Given this list of marker genes DHX9 (NCBI Gene Id 3450), UBA52, RIPK3, DDX41, NFKB1, ZBP1, XRCC6, CTNNB1, CGAS, XRCC5, POLR2E, STAT6, RELA, NFKBIA, RIPK1, POLR3K, POLR1C, RPS27A, NFKB2, POLR2H (NCBI Gene Id 5437), TRIM21, IKBKG, NLRC3, NKIRAS1, IKBKB, IFI16, NFKBIB, TICAM1, POLR3G, AIM2, CRCP, TREX1, POLR3A, TBK1, IRF7, POLR3C, DTX4, POLR1D, CREBBP, STING1, POLR2K, TRIM32, POLR2L, POLR3E, UBC, CHUK, PRKDC, POLR3H, EP300, NLRP4, POLR3D, IRF3, TLR3, DHX36, NKIRAS2, TRIM56, MYD88, POLR2F (RNA polymerase II, I and III subunit F), POLR3GL, UBB, LRRFIP1, MRE11, POLR3F, POLR3B, here is a description of the gene set: studied in species Homo sapiens Human Gene Set: REACTOME_CYTOSOLIC_SENSORS_OF_PATHOGEN_ASSOCIATED_DNA Cytosolic sensors of pathogen-associated DNA